The following is a description of a gene set: Mouse Gene Set: GOBP_DGMP_METABOLIC_PROCESS The chemical reactions and pathways involving dGMP, deoxyguanosine monophosphate (2'-deoxyguanosine 5'-phosphate). studied in species Mus musculus, and this is the list of marker genes: Gda, Nt5c1a, Uox, Nt5c, Urad, Pnp, Xdh, Urah, Guk1, Nt5c2, Dck, Dnph1